Given this list of marker genes GLI1, PAM16, SLC35D1, NOG, KCNE5, GPC6, KCNA1, MGP, WNT5A, CBL, POLE, CD96, DACT1, BUD23, DCLRE1C, ANAPC1, HOXA13, FANCB, PRMT7, USB1, TPM2, TSHR, SNIP1, MRPS28, CDC45, HDAC8, ZNF407, TCTN2, CCNQ, CDKN1C, GPX4, RB1, REV3L, RSPRY1, PIGU, PPP3CA, NHS, FIG4, SKIC3, GJA8, DMP1, EBF3, SMOC1, CILK1, CHN1, EED, WDR35, PARN, CASR, SMO, TBL2, IQCB1, MAN2B1, PITX1, HOXA11, SIL1, KCNH1, KIF22, RAD21, CHEK2, PALB2, LTBP3, CHD7, NPHP3, FN1 (NCBI Gene Id 2335, fibronectin 1), PHLDB1 (pleckstrin homology like domain family B member 1), SKI (SKI proto-oncogene), DKC1, MPZ, ADNP, SEC24D, ATP6V1B2 (NCBI Gene Id 526), FGF9, PIGL, ATR, SDCCAG8, PIK3R1, SMAD6, PEX13, NPHP4, CEP164, COL1A1, CBFB, HDAC4, ZNF469, MTHFS, MASP1, BHLHA9, HYLS1, ZMIZ1, NKX3-2, LMNA, PTPN11, MMP2, FBXO11, PHEX, CCN6, TRPV4, IARS2, COG1, CDT1, IFT80, MAPK8IP3, NFIX, TRAPPC2, SLC34A3, DYNC2I1, ALX4, DNMT3A, LMOD3, HSPG2, THRB, PTDSS1, RUNX2, CREBBP, PIK3CD (NCBI Gene Id 5293), MCTP2, PWAR1, GALNS, PEX16, SIAH1, CKAP2L, BAZ1B, CASK (calcium/calmodulin dependent serine protein kinase), SRP54, TRPV6, BRCA2, SETBP1, TMEM270, EIF4A3, PIGQ, VAC14, RAB34, HPGD (NCBI Gene Id 3248), SMAD4, B3GAT3, COL9A3, TRPS1, RAF1, LRP5, GRM7, ARSB, PTHLH, KIF15, PIGS, SPRED1, ENPP1, COG5, UBE2T, CLDN16, STX5, PACS1, SNX10, CCDC134, PRKD1, RIPK4, OTUD6B, MRAS, B2M, LZTFL1, SUZ12, MACROH2A1, PEX19, RBM8A, HNRNPA1, PDGFRB, LEMD2, PIGT, KIF1A, XRCC2, DNAJC21, CCDC8, LHX4, TNFSF11, RNU4ATAC, TBXAS1, GTF2I, FLNB, FBN2, PISD, NEU1, RAG2, B3GALT6, ESR1 (NCBI Gene Id 2099), TBCD, CHST3, SVBP, TREX1, MAP2K1, TBX5, AMER1, FDFT1, TRIM8, NDUFAF6, SCN1B, GNAS, KANSL1 (KAT8 regulatory NSL complex subunit 1), POGZ, COLEC10, TBX4, MAF, TINF2, INVS, FZD2, KIF7 (NCBI Gene Id 46), TYROBP, TPO, FANCA, VPS33A, ZSWIM6, TTI1, TFE3, TMEM53, EZH2, MYSM1, ORC6, TP53 (NCBI Gene Id 7157), BCR, BMPR1B, SRY, IFIH1 (NCBI Gene Id 64135), NCF1, IL6ST, BMPR1A (bone morphogenetic protein receptor type 1A), BICD2, ACAN, MIA3, FAT4, EXOSC2, HEATR3, BRIP1, MMP13, CPLANE1, KCNJ8, CTC1, ITPR1, IFT172, TRIM37, NSMCE2, FAM111A, SLC26A2, CLCN5, CRKL, ERCC4, TAPT1, GPC4, SCUBE3, CCDC47, CLTCL1, CYP27B1, SLX4, ZNF141, IQCE, SUCLG1, HDAC6, PRDM5, IYD, SRCAP, NXN, ELN, SMC1A, CYP19A1, VPS35L, FGF23, TWIST1, DUOX2, P4HTM, NOTCH2, FKBP6, FANCM, EFL1, TRAIP, IPO8, PEX2, RINT1, PEX14, SBDS, H3-3B, SLC35B2, SERPINF1, SF3B2, POP1, NRAS, DMXL2, EXTL3, MYF5, PLEKHM1, LARP7, TERC, ADAMTSL2, PRKAR1A (protein kinase cAMP-dependent type I regulatory subunit alpha), LETM1, EFNB1, DHX30, SPRED2, CPLX1, SHOX, TENT5A, GNAS-AS1, MEIS2, KLHL41, PIK3C2A, C1GALT1C1, PYCR2, WDR19, TMEM237, GNPAT, CDC6, ARX, ANTXR2, PEX12, CC2D2A, GRIN1, PIGP, RMRP, FLI1, SNORD115-1, POLR1A, FBXL3, RPS6KA3, TREM2, COMP, KCNJ2, FANCF, GNPNAT1, ATRIP (ATR interacting protein), FGFRL1, SOS2, ESCO2, IFT56, TBX15, TCIRG1, MED12, CA2, TMEM165, PPIB, RAB23, RAD51 (RAD51 recombinase), MAP2K2, PLOD3, CTNS, KCTD1 (potassium channel tetramerization domain containing 1), CCN2, PUS3, IDS, PCNT, KAT6B, WDR26, NPM1, RETREG1, LZTR1, ERI1, XYLT2, AIFM1, SHH, EIF4H, NHP2, ZNF668, KCNN3, ABCC9, RTEL1, GMNN, PMP22, FERMT1, MUSK, IFT57, TXNDC15, RECQL4, AIP, ADAMTS10, SGMS2, NADSYN1, TAF6, PLAAT3, PLOD2, GJA1, UFSP2, METTL27, IHH, TERT, GLB1, PEX3, DVL3, PUF60, SLC2A10, FAM20C, DYNC2LI1, BMP2, FANCD2, MAN2C1, TOMM7, GGCX, GJA5, RFC2, EVC, MAGEL2, SCN2A, NPHP1, B3GLCT, B9D2 (NCBI Gene Id 80776), CSGALNACT1, GNAO1, NEPRO, BRAF, ERCC1, POLRMT, EFEMP2, TNFRSF11B, DNA2, EVC2, GPC3, RSPO2, TMEM216, IFT122, SOST, CTCF, MTX2, SLC31A1, CDKL5, BMP1, GAN, NSDHL (NAD(P) dependent steroid dehydrogenase-like), PEX1, EXOC6B, NDN, PRKG2, TBX22, SERPINH1, AFF4, GPR101, OFD1, ARCN1, LYSET, WLS, CENPE, SLC17A5, LRRK1, SNRPN, TNFRSF11A, COL2A1, LIG4, MLXIPL, CLIP2, CREB3L1 (NCBI Gene Id 90993), WDR62, PROP1, VPS13B, NSUN2, ALPL, RLIM (NCBI Gene Id 51132), APC, DHODH, NEB, CEP120, EBP, ACVR1, VDR, CYP2R1, SH3PXD2B, HERC2, HESX1, ALG12 (NCBI Gene Id 79087), PYCR1, MAP3K7, LIMK1, LIFR, POR, COLEC11, ORC4, SMC3, BICRA, SCARF2, PHYH, CWC27, CYP26B1, COL9A2, AFF3, HS2ST1, ZIC3, GNPTG, TRPM3, INPPL1, WNK1, DPYD, HARS1, CBS, ALG3, TUBB3, KDELR2, DNM1L, B9D1, RPS19, CYP3A4, ANO5, ANTXR1, TYMS, TBX3, GDF5, HHAT, ZMPSTE24, CHSY1, PCYT1A, SPART, SIK3, NEUROD2, G6PC3, RPL26, TMEM67, IDUA (NCBI Gene Id 3425), MTAP, POC1A, PNKP, TCF4, JAG1, ATRX, FGFR1, BRD4, EHHADH, TG, CDC42BPB, SLC32A1, IL7R, B4GALT7, FLNA, CSPP1 (centrosome and spindle pole associated protein 1), GLI3, SUMF1, POLR3A, ALG9, IL2RG, TGFB1, SPARC, RPL13, ATP6V0A2, COL11A1, SQSTM1, RBBP8, LMBR1, SCN9A, RBM10, SLC35A2, MECOM, DNAJC30, QRICH1, SP7, GTF2IRD2, COL1A2, GUSB, CUL7, ZNF699, TGDS, PEX11B, FKBP10, RRAS, TMEM231, TSHB, PRKACB (protein kinase cAMP-activated catalytic subunit beta), CANT1, IFT81, PDE4D, SNORD116-1, PLCB3, NEK1, BRF1, ANKH, RIT1, CFL2, RBPJ, ERCC6, OBSL1, FANCE, RAD51C, TMEM107, DDRGK1, TRIP11, SLC25A22, FBN1, TCTN3, PEX10, HEPHL1, DYM, ATP7A, EIF2AK3, SLCO2A1, IFT140, NUP85, GSC, PORCN, BMP4, WNT7A, ZEB2, KRAS, NANS, PTCH1 (NCBI Gene Id 8015), VCP (NCBI Gene Id 94731), COL10A1, FGF10, ASXL2, PLXND1 (NCBI Gene Id 23652), STX1A, UGP2, MKRN3 (makorin ring finger protein 3), SLC5A5, LEMD3, VPS37D, PTH1R, LPIN2, ZPR1, LRP4, NOTCH3, DUOXA2, AGA, GATAD2B, PEPD, HNRNPR, ARSL, BCOR, FGFR3, BGN, DHCR7, CEP290, SCN4A, BPNT2 (3'(2'), 5'-bisphosphate nucleotidase 2), CRTAP, WRAP53, GORAB, ASCC3, RET, NF1, DONSON, IDH1, EXT1, MED25, SPTBN1, GLE1, MAD2L2, RPGRIP1L, GATA4, POU1F1, CTBP1, MKS1, MEGF8 (multiple EGF like domains 8), PLK4, RRAS2, RTL1, COG4, MATN3, NSD1, TBCE, SETD5, PWRN1, CAMK2A, CLCN7, IFT43, MAFB, IDH2, NEK8, LBR, SLC10A7 (NCBI Gene Id 84068), SLC34A1, OSTM1 (osteoclastogenesis associated transmembrane protein 1), DVL1, PIEZO2, ROR2, MET (MET proto-oncogene, receptor tyrosine kinase), PDE3A, SMARCA2, MEG3, GNS, XYLT1, SATB2, NSD2, INTU, HNRNPA2B1, FGF16, GEMIN4, SF3B4, EP300, ZBTB20, FGFR2, IFT52, PAPSS2, ITCH, SALL1, ACTA1, CFAP410, SOX9, GNPTAB, SALL4, ORC1, PSMD12, COL11A2, UNC45A, HOXD13, PRKACA, RASA1, ACSL4, SOS1, BRCA1, NIPBL, GTF2IRD1, SLC39A13, PPOX, PEX26, FANCC, STX16, DYNC2H1, PEX5, TCTN1, LTBP1, P3H1, ARSK, RERE, TRAF3IP1, SLC29A3, DDR2, TMEM38B, KIAA0586, MIR140, TBC1D7, P4HB, PEX6, DLK1, NPR2, RASA2, USP9X, KAT6A, LAMA5, SNRPB, COL9A1 (NCBI Gene Id 1297), NAA60, EXT2, MBTPS2, MGAT2, FIBP, MMP9, SIK1, TONSL, NPR3, TWIST2, GHR, FANCG, TTC21B (tetratricopeptide repeat domain 21B), RAB33B, CSF1R, KNSTRN, PTEN, KIAA0753 (KIAA0753), HINT1, HNRNPH1, AGPS, NOP10, MAPK1, MSX2, SLC2A2, FANCL, ADAMTS2, ADA, CENPT, AMMECR1, HS6ST1, ROBO1, HSPA9, RPGRIP1, NMNAT1, TBC1D2B, RAG1, RFWD3, LHX3, LONP1, FANCI, DCHS1, ACP5, SON, NEK9, CEP152, SMARCAL1, DYNC2I2, PCDHGC4, SFRP4, UBAP2L, HBB, PEX7, H3-3A, RAB3GAP2, ERCC8, AXIN1, NPAP1, BPTF, OCRL (OCRL inositol polyphosphate-5-phosphatase), here is a description of the gene set: studied in species Homo sapiens Abnormal long bone morphology Human Gene Set: HP_ABNORMAL_LONG_BONE_MORPHOLOGY An abnormality of size or shape of the long bones.